The following is a description of a gene set: Human Gene Set: REACTOME_RRNA_MODIFICATION_IN_THE_NUCLEUS_AND_CYTOSOL rRNA modification in the nucleus and cytosol studied in species Homo sapiens, and this is the list of marker genes: WDR75, NOC4L, NOP2, RPS9, UTP25, DIMT1, DDX49, PNO1, DCAF13, RRP9, DHX37 (DEAH-box helicase 37), RRP7A, DKC1, WDR36, BMS1, WDR43, THUMPD1, IMP3, UTP14A, UTP3, DDX47, RCL1, DDX52, EMG1, TBL3, PWP2, NOP56, UTP15, NOP10, NAT10, WDR3, RPS6, WDR46, TSR3, UTP6, RPS7, NOL6, RRP36, UTP18, UTP20, FCF1, RPS14, GAR1, UTP11, HEATR1, UTP4, NOP58, BUD23, KRR1, NOP14, MPHOSPH10, NHP2, SNU13, PDCD11, FBL, NOL11, IMP4, TRMT112, UTP14C, RPS2